The following is a description of a gene set: studied in species Homo sapiens Genes in the cancer module 367. Human Gene Set: MODULE_367, and this is the list of marker genes: CXCR4, RHO, BDKRB1, P2RY2, CCKBR, DGKI, BDKRB2, PRKD3, AVPR1A, DGKA, P2RY6, LPAR1 (NCBI Gene Id 1902), AGTR1, CCR1, C3AR1, GNA15 (G protein subunit alpha 15), GAP43, PLCD1, CCR5, OXTR, F2RL2, CCR2, SAG, HTR2B, CXCR2 (C-X-C motif chemokine receptor 2), LTB4R, EDNRB, CXCL13, P2RY1